Given this list of marker genes HSP90AB1, KLRD1, HSPA8, TAPBP (NCBI Gene Id 6892), HLA-DMA, HLA-DQB2, CYRIB, HLA-DPA1, HLA-DQA1, HLA-DQA2, HLA-DRB3, CD8A, CD81, HLA-DRA, HLA-DRB4, TAPBPL, ANXA11, LILRB1, CD4, YWHAE, CD74, KLRC1, B2M, ATP1B1, MS4A1, HLA-DRB5, HLA-DQB1, CD160, KLRC2 (killer cell lectin like receptor C2), LILRB2, HLA-DOA, HLA-DMB, HLA-DRB1, HLA-DPB1 (major histocompatibility complex, class II, DP beta 1), HLA-DOB, PKM, HSP90AA1, here is a description of the gene set: Binding to a major histocompatibility complex. studied in species Homo sapiens Human Gene Set: GOMF_MHC_PROTEIN_COMPLEX_BINDING